Given this list of marker genes Prkn, Adora2a, Drd4, Crh (NCBI Gene Id 383938), Ptgs2, Crhbp, Rab3b, Aph1c, Snca, Kcnq4, Slc6a4, Slc6a2, Cntnap4, Drd5, Pmch, Drd1, Gdnf (NCBI Gene Id 14573), Drd2, Th, Flot1, Drd3, Aph1b, Cdk5, Rasd2, Comt, Nat8l, Chrna7, Park7, Pnkd (paroxysmal nonkinesiogenic dyskinesia), Pink1, Chrnb2, Arrb2, Tor1a, here is a description of the gene set: Mouse Gene Set: GOBP_SYNAPTIC_TRANSMISSION_DOPAMINERGIC species: Mus musculus The vesicular release of dopamine. from a presynapse, across a chemical synapse, the subsequent activation of dopamine receptors at the postsynapse of a target cell (neuron, muscle, or secretory cell) and the effects of this activation on the postsynaptic membrane potential and ionic composition of the postsynaptic cytosol. This process encompasses both spontaneous and evoked release of neurotransmitter and all parts of synaptic vesicle exocytosis. Evoked transmission starts with the arrival of an action potential at the presynapse.